Given this list of marker genes SRP9, ARL6IP1, GJD2-DT, SSR1, SRP54, SRPRB, SEC62, SRP14, RN7SL3, SSR3, SNAP25-AS1, SEC61A1, SEC61A2, ZFAND2B, ENSG00000283175, RN7SL2, SRPRA, SRP72, SRP68, TRAM1L1, BHLHE40-AS1, SEC63, RN7SL1, SEC61B, SIL1, SSR2, TTC9-DT, SRP19, TRAM2, TRAM1, here is a description of the gene set: The targeting of proteins to a membrane that occurs during translation. The transport of most secretory proteins, particularly those with more than 100 amino acids, into the endoplasmic reticulum lumen occurs in this manner, as does the import of some proteins into mitochondria. Human Gene Set: GOBP_COTRANSLATIONAL_PROTEIN_TARGETING_TO_MEMBRANE studied in species Homo sapiens